The following is a description of a gene set: from publication Chen Y, Wang X (PMID 31504780) Human Gene Set: MIR4252 Genes predicted to be targets of miRBase v22 microRNA hsa-miR-4252 in miRDB v6.0 with MirTarget v4 prediction scores > 80 (high confidence targets). species: Homo sapiens, and this is the list of marker genes: MANEAL, NAP1L4, ADAM23, JRKL, MEI4, WWTR1, RAB9B, ENTPD4, AK2, EFNB3, GARS1, STOML2, TULP4, ICA1L (NCBI Gene Id 65068), HFM1, SAE1, USP37, BCLAF3, SLC2A13, MAP1B, SRGAP2, WIPI2, MFSD4B, DIXDC1 (DIX domain containing 1), SPRTN (NCBI Gene Id 83932), PGS1, EIF5A2 (NCBI Gene Id 57114), SLC39A10, SLC25A45, IAPP, ARL4A, TRNP1, AKIRIN2, DDX3X, RAB5B, WSB2, USH2A, TAOK1, MED9, PCYOX1, CDK6 (cyclin dependent kinase 6), HPSE2, LGR5 (leucine rich repeat containing G protein-coupled receptor 5), GIMAP1, SYNPR, OTOF, ERC2, DYRK2, GGACT, AK7, PALLD, TRPC3, SLC4A7, KHDC4, E2F4, CRKL, NAA15, FCRL1, LMTK2, SCRN1, UBQLN4, PTAR1, IMP3, KLHL29, RFK, SMPDL3B, LAMC1, ATP2A2, ST3GAL3, JPH3, DAAM1, FNDC3A, TBC1D5, WASF1, TRANK1, TTC7B, KLHL3 (kelch like family member 3), RAB2A (RAB2A, member RAS oncogene family), ZFYVE16, AGBL5, ZNF99, FCHSD2 (FCH and double SH3 domains 2), PDCD10, KCNK10, ABCG8, RHPN2, ADAMTSL3 (ADAMTS like 3), RYBP, PRKG1, MED13, RAB3B, AKIRIN1